The following is a description of a gene set: Mouse Gene Set: GOBP_CELLULAR_COMPONENT_MAINTENANCE The organization process that preserves a cellular component in a stable functional or structural state. studied in species Mus musculus, and this is the list of marker genes: Cntnap2, Kifc3, Sema3a, Grin2b, Rimbp2, Cbln1, Clrn2, Lypd10, Dgkz, Cfl1, Csmd2, Cd177, Fermt2, Fcgr2b, Bsn, Itga3, Ins1, Trem2, F2r, Appl1, Mpp2, Ckap5, Syngap1, Neat1, Zmynd8, Cbln3, Nrxn1, Grin1, Nedd9, Ctbp2, Prnp, Kirrel1, Rims2, Homer1, Grn, Rapsn, Cadm1, Camsap3, Shank1, Sdf4, Ins2, Plekha7, App, Nlgn1, Erc2, Adgrl3, Apoe, Pkp1, Tanc1 (NCBI Gene Id 66860, tetratricopeptide repeat, ankyrin repeat and coiled-coil containing 1), Prickle2 (prickle planar cell polarity protein 2), Prtn3, Fyn, Cldn1, F2rl1, Igf1r, Mpz, Pick1, Afdn, Lnpk, Prickle1, Adgrb3, Arf6, Abl2, Ophn1, Insr, Pjvk, Cldn3, C1ql1, Sort1, Whrn, Cttn, Mtss1, Csf1r, Dsc1, Myocd, Hspa8, Pard6a, Shroom2, Tjp1, Abhd17b, Tprn, Cntnap1 (contactin associated protein-like 1), Cbln2, Vps35, Itgb3, Zfp804a, Dlg2, Rims1, Epb41l3, Itpka, Mtmr2, Erc1 (NCBI Gene Id 78063), Rab3a, Plxna4, Lypd11, Pkp2, Dlg1, Elmod3, Itgb1, Inava, L1cam, Shank3, Pclo